Given this list of marker genes H2BC26 (NCBI Gene Id 128312), H2BC12, MPG, H2BC12L, H2BC5 (H2B clustered histone 5), H2AC14, H2BC17, POT1, H2BC21, TERF2IP (TERF2 interacting protein), H2AB1, H2BC13, TERF1, OGG1, H2AC4, H2AC7, H2BC4, H2BC14, H3-4 (H3.4 histone, cluster member), MUTYH, H2BC15, H2BC11, H2AC18, H2BC3, H2AJ, TERF2, H4C1, H2AC6 (NCBI Gene Id 8334), NEIL3, H2AZ2, ACD, H2BC1, H2BC9, H2AC20, H2AX, TINF2, here is a description of the gene set: part of: Depurination Damaged purines are cleaved from the sugar-phosphate backbone by purine-specific glycosylases. Reactome Pathway: Cleavage of the damaged purine studied in species Homo sapiens